Given this list of marker genes NT5C2, NT5C, GDA, DNPH1, XDH, NT5C1A, GUK1, here is a description of the gene set: The chemical reactions and pathways involving dGMP, deoxyguanosine monophosphate (2'-deoxyguanosine 5'-phosphate). Human Gene Set: GOBP_DGMP_METABOLIC_PROCESS species: Homo sapiens